The following is a description of a gene set: Human Gene Set: GCM_PSME1 Neighborhood of PSME1 species: Homo sapiens Neighborhood of PSME1 proteasome (prosome, macropain) activator subunit 1 (PA28 alpha) in the GCM expression compendium, and this is the list of marker genes: RPS5, PRMT1, CBFB, PSMA6, PSME1, POLR2K, HNRNPU, RPL7, ATP5PB, SNRPF, SNRPA1, RPL6, DUT, ACTG1, PNN, PFN1, NCL, TIAL1, RPL19, PTMA, CAPZA1, APRT, TMSB10, ATP5F1C (ATP synthase F1 subunit gamma), EIF3F, RABGGTB, CFL1, TCEA1, SLBP, MSN, PSMA1, NAP1L1, NDUFA12, HNRNPA1, HPRT1, HMGN1, ILF2, SLC25A3, RPS24, NASP, PSMA5, YWHAZ, H2AZ1, RPL17, COPS5, RPS8, SET, CSNK2B, RPS7, RPL10A, RPL27, SRSF9, SAP18, ZNHIT3 (zinc finger HIT-type containing 3), EPRS1, CLEC18C, SNRPD2, RPL11, EEF1B2, ATP5F1B, ARHGDIB, SUMO2, APEX1, SRSF2, RHOA, HNRNPD, PSMB3, CLIC1, HDAC1, RPL35A, BRD8, PPIA, HNRNPM, POLG, ATP5MC3 (ATP synthase membrane subunit c locus 3), POLR2G, RPS19, NACA, SNRPD3, NPM1, RPL21, IK, PCBP1, TRA2B, KHDRBS1